The following is a description of a gene set: The chemical reactions and pathways involving ribose phosphate, any phosphorylated ribose sugar. species: Homo sapiens Human Gene Set: GOBP_RIBOSE_PHOSPHATE_METABOLIC_PROCESS, and this is the list of marker genes: OLA1, HDAC4, NDUFA2, PFAS, NDUFB9 (NCBI Gene Id 4715), TGFB1, TMSB4X, NADK, PDE10A, SULT2A1, P2RX7, AK9, ALDOC, NUDT10, PAPSS2, RFK, NDUFS6, OGDHL, NME9, PFKFB3, ATP1A2, NDUFA7, GMPR2, RHOQ, SULT1A4, AMPD3, UCKL1, CLPX, TRIM63, PRPS2, ALDOB, NDUFA13, FKRP, NUDT5, DHODH, PDE4C, UCHL1, ADCY8, OGDH, NUDT11, PNP, GCK, GNAI3, ADCY5, IER3, NDUFA11, PAPSS1, ATIC, VCP, BLOC1S6, NDUFB10, HTR2A, HK2, NDUFB1, IMPDH1, PFKFB2, PRPS1, MFSD8, ATP5F1EP2, ATP5MGL, LRRK2, ATP5MJ, NME5, PDE5A, PGK1, GUK1, PGAM4, SULT2B1, ADK, SLC2A6 (NCBI Gene Id 55587), ENO1, MTHFD1, TREM2, ATP6V1B2, ACTN3, PDE2A, ATPSCKMT, SULT1C4, NME7 (NME/NM23 family member 7), CDA, TIGAR, NUDT3, NME2P1, NT5E, NDUFB4, MYH8, RORA, SLC4A4, ATP5MF, MAGI3, ATP5MC2 (ATP synthase membrane subunit c locus 2), NDUFC2, ARL2, SDHD, FIGNL1, SULT1A1, FAM3A, LRGUK, MT-ATP6, NUDT4, MT-ND4, NDUFB5, PRPSAP2, SPHK2, MIR675, IFNG, ABCC9, AMPD2, ATP5PO, BPGM, XDH, NDUFA5, GUCY2D, MYH3, NDUFB6, GPI, PSEN1, PDE1A, NME1, PDE4B, ENTPD4, SDHB, PGAM2, CTNS, ABCC6, G6PD, CMPK1, ATP7A, ADCY9, NUDT14, ATP5F1C, ADCY10, ATP6V1A, ATP5ME, PARP1, ZBTB7A, ADCY2, PRPSAP1, MYH4, RNASEH2B, ENO4, BEND3, DLG1, NCOR1, GIMAP7, PDE8B, EP300, GMPS, COX11, ADCY4, PRKAA2, ALDOA, MFN1, PDE7A, PGAM1, PRKAG2, ADSS1, NPPA, GUCY1A2, GALK1, ENO2, EFL1, PFKL, NME2, SLC25A13, PRXL2C, PINK1, HK1, OPA1, ENPP1, NDUFA10 (NADH:ubiquinone oxidoreductase subunit A10), UCK1 (NCBI Gene Id 83549), PRPS1L1, NUDT2, MPP1, BAD, NPPC (natriuretic peptide C), ATP5F1A, NDUFS3, NDUFAB1, MYH7, TPST2, ATP5PD, PRKAA1 (protein kinase AMP-activated catalytic subunit alpha 1), UPRT, PARG, NDUFS5, NDUFS4, GPD1, NT5C, PGK2, ANTKMT, NDUFA12, ATP6V1B1 (NCBI Gene Id 525), NDUFS7, NUDT18, MT-ND3, BPNT1, ENTPD5, PPP2CA, UCP2, UMPS, NDUFS1, CARD11, SULT1A2, TPST1, EPHA2 (EPH receptor A2), PFKM, AMPD1, PRKAG1, ABHD14B, LIPA, RPTOR, ATP5F1E, FIS1, ADPGK, COL6A1, NME3, CTPS2, IMPDH2, HINT1, DNM1L, RAB23, LDHC, PFKFB1, MT-ND4L, MT-ND2, IGF1 (insulin like growth factor 1), ADA, CACNB4, PDE4A (NCBI Gene Id 5141), ITPA, FOXK1, NDUFA9, DHTKD1, MAP2K1, NDUFA6, ADCY3, SDHA, AK3, ADCY6, PFKP, NME4, ENPP3, FOXK2, HPRT1, MT-ND1 (mitochondrially encoded NADH:ubiquinone oxidoreductase core subunit 1), HSPA1A, TREX1, NT5C1A, PTHLH (parathyroid hormone like hormone), AK1, FBP1, ATP5F1D, PRKN, PRKACA, GIT1, ADSS2, GUCY2C, GART, UCK2, SRC, DDIT4, MT-ND5, PDE8A, CBFA2T3, TJP2, MLST8, NDUFA3, RAN, NDUFB2, SULT1C3, NDUFA8, ATP5MC1, ADSL, NDUFV1, NDUFV3, PRKAG3, NDUFA1, PTH, EIF6, AK4 (NCBI Gene Id 387851), HSPA8, HIF1A (NCBI Gene Id 3091), MT-ND6, DMAC2L, PDE7B, ENTPD1, MYH6, NPPB, TPI1, NPR1, GUCY1B1, PDE4D, NUDT4B, UPP2, LETMD1, SULT1A3, PKM, UQCC3, ATP5MG, GAPDHS, MTOR, ENTPD7, GTPBP1, KAT2B, NT5C2, ATP6V0C, ATP1B1, DPYD, UPP1, NDUFS2, MLXIPL, VPS9D1, CASK, IL4, ATP5PF, NDUFB3 (NADH:ubiquinone oxidoreductase subunit B3), UPB1, SIRT6, GDA, CAD, ATP5MC3 (NCBI Gene Id 518, ATP synthase membrane subunit c locus 3), DNAJC30, AK2, MT-ATP8, STAT3, SULT1B1, HSPA1B, ATP5MK, NDUFS8, LDHA, PAICS, PRTFDC1, FLCN, HK3, ATP5IF1, INSR, STOML2, APRT, NDUFB11, DCK, ADCY7, PID1, ENO3, HKDC1, SULT1E1, PPAT, PPARA, PDE9A, TSPO, SLC25A25, NME6, SELENON, APP, ARNT, OGT, ZBTB20, GUCY2F, GUCY1A1, AK5, NDUFB7, NPR2, ADCY1, CTPS1, JMJD8, NMNAT1, NUPR1, SLC4A1, ATP5F1B, TAFAZZIN, BCL2L13, ATP5PB, INS, SDHC, DLG2, NUDT9 (nudix hydrolase 9), PGM1, NDUFC1, MTCH2, NDUFB8, DPYS, PKLR, GAPDH, NDUFV2